Given this list of marker genes SERINC5 (NCBI Gene Id 256987), ANGPT2, USE1, TOB1, PCYOX1, ITGAE, MCMDC2, MDM4, TMEM241, CNTNAP3, CYP4F3, RAPGEF4, RPS16, GPER1, TGIF1, HBB, NUP43, RPS25, ASB3, DEFT1P, SPATA2, MANSC1, RPL7, GUSBP3, ENSG00000272447, ZDHHC18, MMP8, VAMP1, GDA, UBL7-DT, OLFM4, PI3, PITPNA-AS1, KYAT3, MAP2K5, AMPH, ZNF81, SLC33A1, ALDH6A1, ABCG5, YPEL2, PPEF2, ZNF540, JRK, STMN3, CD1C, NSUN7, TMEM161B-DT, IQCF5, THEM4, RPS11, BTF3, ADI1, SH3GL1P1, NOP53, ZNF554, EIF3F, NR2F6, ADAMTS9-AS2, RSPRY1, GPBP1L1 (GC-rich promoter binding protein 1 like 1), COL5A2, AFF3, AGO2, RPUSD3, SNX1, ZNF830, NEURL4, ZNF85, SLC26A11, PRDX2, PRPF38B, WNK4, KDM4B, DSEL, DDX42, SIGLEC15, ZNF280C, DDX19A, RSL1D1, RAPH1, MMEL1, PTDSS1, SCARNA15, RPS23, MRPL30, RPS28, DOK7, ZNF563, ZSCAN25, C2orf92, PROSER3, DNAI7, NDUFS8, EPRS1, RPL6, ELMOD1, MAL2, TCF3, SLC6A14, REPS1, FAM21EP, NOM1, ALPL, TREX2, AFG3L2, L1TD1, SLC11A2, SNX22, TRAF3IP1, SLC27A1, EIF3L, LANCL1, UBE2J2, SIMC1P1, SPATA6, EME1, GDF10, NFATC2IP (NCBI Gene Id 84901), CRISP3, ABHD18, DRC12, DEFB114, APH1A, EXOSC6, CAMP, SLC25A6, SYCE2, TMEFF2, LINC00663, EYA4, TPT1, AFDN-DT, ZNF486 (NCBI Gene Id 90649), HYDIN, CFAP90, RNF133, FXR1, MFSD4B, PCDH11X, DCHS1, FA2H, DPP10, CIITA, AKR7A2, ANKRD30B, MRPS25, ITGB8, NFIB, CEACAM8, ZNF491, BMS1P2, PAXIP1-DT, FLRT3, ANP32B, LUC7L3, CFLAR-AS1, ZNF587, CPA1, EEF2K, LTA4H, SERPINA7 (serpin family A member 7), ERCC1 (ERCC excision repair 1, endonuclease non-catalytic subunit), RFLNB, IFT81, TEX22 (testis expressed 22), GANAB, FAM228B (family with sequence similarity 228 member B), HSD17B7 (NCBI Gene Id 63064), UGGT1, MRPL45, SORL1, MATN3, SLC25A29, ORAI2, DYDC1, RPL9, LARP6, COX19, TPTE2P6, SCN10A, TRIM39, FUT8-AS1, RSRP1, COLCA1, CAPN14, CTTNBP2, KRT10, here is a description of the gene set: Human Gene Set: GSE13485_DAY3_VS_DAY7_YF17D_VACCINE_PBMC_UP species: Homo sapiens from publication Querec TD, Akondy RS, Lee EK, Cao W, Nakaya HI, Teuwen D, Pirani A, Gernert K, Deng J, Marzolf B, Kennedy K, Wu H, Bennouna S, Oluoch H, Miller J, Vencio RZ, Mulligan M, Aderem A, Ahmed R, Pulendran B (PMID 19029902) The immune responses generated by YF-17D by profiling genes in 25 vaccine recipients were accessed at days 1, 3, 7, and 21 post-vaccination compared to pre-vaccination in PBMCs. The immune responses generated by YF-17D by profiling genes in 25 vaccine recipients were accessed at days 1, 3, 7, and 21 post-vaccination compared to pre-vaccination in PBMCs. Genes up-regulated in comparison of unstimulated peripheral blood mononuclear cells (PBMC) 3 days after stimulation with YF17D vaccine versus PBMC 7 days after the stimulation.